The following is a description of a gene set: Genes containing one or more binding sites for (ZNF830) in their promoter regions (TSS -1000,+100 bp) as identified by GTRD version 20.06 ChIP-seq harmonization. species: Homo sapiens Human Gene Set: ZNF830_TARGET_GENES from publication Yevshin I, Sharipov R, Kolmykov S, Kondrakhin Y, Kolpakov F (PMID 30445619), and this is the list of marker genes: PAPLN-AS1, MRPS10, COG8, JAG1, TTC5, SDR42E1, ARHGEF1, TRIM41, SHOC2, STXBP3, NIP7, LZTS3, SKIC2, PPM1D, SEPTIN7, ARHGEF19, PPP4R4, C11orf71, ZNF264, TFB2M, ABCD4, SSRP1 (NCBI Gene Id 6749), RAB2B, LINC03021, USP3, SHKBP1, FAM83C-AS1 (FAM83C antisense RNA 1), GAPDH, ZKSCAN4 (zinc finger with KRAB and SCAN domains 4), ZNF35, PPP1R13L, WIZ, SNRPE, UQCRC2, NDUFB2-AS1, PPP1R2, RREB1, MIR4638, WNT1 (NCBI Gene Id 7471), COG1, RARA, RNF216, MBTPS2, TRIM7, CD2BP2, TBC1D12, MRPL13, ZNF271P, AAR2, RAB33B, SNHG25, POLR1HASP, RAD1, ZKSCAN5, GGA1, THOC1-DT, EIF3A, PRADC1, ZNF598, CIPC, METTL18, TPM4, ZSCAN30, HEYL, ACVR1C, RUFY3, PTGR3, ANO7L1, SNORD104, TBCCD1, ESR2, DECR2, AHDC1, RNF32, FIG4, SLC2A4, LRRC47, NDUFB7, PGRMC2, PFDN5, XNDC1N, SCYL3, PRPSAP1, TOE1, PLCG2, IFT81, MILIP, HES6, PSMD14, COX7A2, MVB12A, PLEKHG4, PDP1, ZKSCAN8, NCBP3, BANF1, NDUFB2, CCT7, TBC1D8B, RBM7, CCNF, UBE2Z, UBR7, VRTN, C17orf58, TSEN54, POLR1H, EIF1AD, EIF5 (eukaryotic translation initiation factor 5), RNF121, SLC35A1, BAX, ZNF629, MRPS33, FUNDC2, PDE8A, TFEB, CKAP2, PSCA, EEF1DP6, ATP6V1D (NCBI Gene Id 51382), ABTB2, KDM1A, EEF1AKMT2, PCBP2, MDC1, VPS16 (NCBI Gene Id 64601), PCED1A, LRRC59, DBIL5P, ZNF197, CKAP2-DT, SLC4A11, JRK, MVP-DT, TACC1, FAM200A, HUS1, LDHA, ILK, CDIPT, UBE2I, TENT5B, COX6B2, NPW, WDR75, MIR378D2HG, RPS7, ZSCAN25, SPCS2, DNAJB11, EIF6, NDN, COPS9, SNAP29, FAM177A1, PRPF18, LBHD1, ARK2N, RFC3, STUB1-DT, MFSD12, ZSCAN12, PSMB7, BBIP1, G2E3, HIBCH, ZNF3, THOC1, DET1, C6orf120 (chromosome 6 open reading frame 120), PI4KA, FOXA3, SPHK2, SH2B1, UQCC3, ATG101, POLR1G, POLQ, PHPT1, RAVER1, ENSG00000267424, BAZ1B, RABGAP1 (NCBI Gene Id 23637), SNHG17, SLC35A5, ZNF16, COX17, FIRRM, BRIX1, POLR2C, KANK3, LTBP4, SLBP, GLCCI1-DT, CERNA3, HDAC8, E2F6, MRPL12, GLCCI1, SH3BGRL2, AP3B2, BIK, ZSCAN9, RPL32P27, C8orf88, RPS20, SNORA50C, DHX8, SIGIRR, PRRT2, SRSF8, PSMD14-DT, DNAJC7 (NCBI Gene Id 7266), LINC01023, TM9SF1, RPL18, POLR3C, ZNF768, WDR27, ZCCHC4, EIF2S1, CNTROB, CACYBP, RGS12, VRK3, CCDC63 (NCBI Gene Id 160762), ASPSCR1, ENSG00000260136, RPL7L1, ZSCAN26, MTBP, ZNF142, ARL14EP, ATG3, MDM4, RNF115, RPS14, NEK4 (NIMA related kinase 4), SNORD54, GPR160, NELFE, SMARCD1, MUTYH, RBM25, ZKSCAN1, CCDC65, PGF, YLPM1, RTN4RL2, PAXBP1, COL9A2, CYLD, RTBDN, BCL2L11, BCS1L, AK9, PAIP2B, SH3GL1, ZNF396, CNST, ZNF572, RPL10, CNOT8, SLC44A1, NR1H2, TOX4, GAPDH-DT, TIMM10, SYMPK, DNAAF3, COPS4, TBPL1, CDIPTOSP, EPCIP-AS1, ZNF473, RRP8, STUB1, FIS1, VIM, UBXN6, XRRA1, CASKIN2, EIF5-DT, ZNF280C, MAFG, CFDP1 (craniofacial development protein 1), ERCC1